The following is a description of a gene set: from publication Chen Y, Wang X (PMID 31504780) Human Gene Set: MIR7849_3P Genes predicted to be targets of miRBase v22 microRNA hsa-miR-7849-3p in miRDB v6.0 with MirTarget v4 prediction scores > 80 (high confidence targets). species: Homo sapiens, and this is the list of marker genes: SKIL, SLC35A3, PUM1, NPAS2, DCP1B, BNC2, POLR3GL, ZNF608, BTBD7, PDHA1, CUL3, UBQLN2, GRIA2, SEMA5A, LIN7C, CPSF6, ZC3H4, LRRTM3, SANBR, CENPU, BMAL1, ASCL4, CASKIN2, GRHL1, FLT1, FBXO5, HIPK3, NET1, RRAGB, ELK3, ANKRD42, AGBL4, RIMKLB, ZNF716, STC1, FAM76B, ALCAM, PKIA, SLBP, TMEFF2, ZBTB41, ZNF706 (NCBI Gene Id 51123), IER5L, GCLM, TAOK1, RAD51AP1, TMEM41A, CCNC, TPP2, POGZ (NCBI Gene Id 23126), GPR19, AHDC1, RBL2 (RB transcriptional corepressor like 2), DMD, NEUROD4 (neuronal differentiation 4), PLEKHF2, ACTR3C, ADAM23, STEAP2, PPP4R2, ROR1, VCPIP1, NR4A2, FUT9, METTL15, ANKRD12, PARP8, AKAP1, LHX9, NHSL1, PPP3CA, TBC1D23, SRSF1, NDST3, FNDC3A, SOCS6, NEUROD1, KIF3A, KMT2C, SLC44A1, PNPLA4, HOMER1, SCN3A, TRIM33, GABRB3, STARD13, YES1, MECOM, HCN1 (hyperpolarization activated cyclic nucleotide gated potassium channel 1), OSGIN2, ARID2, GPR22, ADRB2, TBC1D8, FA2H, EIF4A2, ZNF281 (zinc finger protein 281), RAB11FIP2, SMOC1 (NCBI Gene Id 64093), IRX3, UBE2D2, RGS13, PRDM1, ANKRD17, PDLIM5, SH3KBP1, KBTBD2, PTPN2, GALNT1, TET2, TGFBR1, ARPP19, DDX3X, CUL2, NLGN1, KDM2B